Given this list of marker genes RRAGD, RRAGB, ATF2, LARS1, ATF4, SAR1A, MTOR, SESN1, RNF167, SESN2, SESN3, SAR1B, here is a description of the gene set: Human Gene Set: GOBP_CELLULAR_RESPONSE_TO_LEUCINE_STARVATION species: Homo sapiens Any process that results in a change in state or activity of a cell (in terms of movement, secretion, enzyme production, gene expression, etc.) as a result of deprivation of leucine.